The following is a description of a gene set: This event has been computationally inferred from an event that has been demonstrated in another species.<p>The inference is based on the homology mapping from PANTHER. Briefly, reactions for which all involved PhysicalEntities (in input, output and catalyst) have a mapped orthologue/paralogue (for complexes at least 75% of components must have a mapping) are inferred to the other species. part of: Ion channel transport studied in species Mus musculus electronically inferred by orthology from the curated human pathway Reactome Pathway: Stimuli-sensing channels, and this is the list of marker genes: Unc79, Rps27a, Slc9b2, Best2, Trpm4, Trdn, Trpv6, Trpc7, Asic5, Ano7, Trpm8, Scnn1a, Sgk1, Scnn1b, Casq1, Ryr1, Ubb, Calm1, Best3, Scnn1g, Trpv5, Clcnkb, Mcoln1, Tpcn2, Asic4, Mlkl, Ano8, Ano10 (anoctamin 10), Nek4, Trpv2, Trpm6, Clcn4, Fkbp1b, Stoml3, Tsc22d3, Slc17a3, Clcn6, Ttyh3, Ano4, Trpc5, Asic1, Ano5, Clca4b, Asic3, Best1, Trpc1, Trpm5, Trpc4ap, Nalcn, Trpc6, Clca1, Ano9, Ano2, Trpa1